Given this list of marker genes TNF, CXCL2, JADE2, SLC1A3, EZH2, SPECC1L, ICAM4, CDK1, GCH1, IL23A, ZC3HAV1, ITGB8, TRAF1, TBC1D10A, RIN2, RNF144B, LDLR, RIPK2, EHD1, HDGF, FFAR2, CYRIA, TMEM54, ADA, PIK3AP1, TNIP1, IL20, SFR1, BIRC3, SMG9, LINC01138, TNFAIP8, DRAM1, PTPRJ, ANO5, TAGAP, HIVEP1, CASP5, ACOD1, UGP2 (UDP-glucose pyrophosphorylase 2), STK26 (serine/threonine kinase 26), CD83, PTGS2, SOCS3, SESTD1, IFNGR2, TNIP3, PIM3, ADORA2A-AS1, CCL20, PLK3, GPR132, EPM2AIP1, ZBTB10, PFKFB3, TANK, CXCL1, IRAK2, IL1B, MMP7, SERPINB9P1, HCAR3, PSMD5, SGPP2, PDSS1, CCL23, PELI1, TNFAIP2, PTX3, NLRP3, RNF19B, RCSD1, PLA1A, TNFRSF9, CXCL8, TAB2, CXCL3, CSF3, EBI3, RHOF, CCL4, ACVR2A, GBP1, ID2, DNAJA1, CENPU, DUSP2, KCNA3, FRMD7, IL10, AQP9, KCNJ2, ZFX (NCBI Gene Id 7543), NOCT, ICAM1, EPB41L3, TNFRSF10B, ARRB1, MTF1, TLR7, BIRC2, SCN1B, RAP2C, SERPINB8, SNX18, PILRA, MIR155HG, EIF1B, CLCF1, TAOK3, RND1, ARL5B (NCBI Gene Id 221079), QKI, BCL2A1, MCOLN2, DCUN1D3, TNFAIP3, PIM2, IL12B, NFE2L2, PMAIP1, HIVEP2, SOD2, BTG3, NAB1, SIAH2, LINC01465, DENND5A, MIR3142HG, HCP5 (NCBI Gene Id 91955), MIR3945HG, SUSD6, SLC2A6, SAV1, PSMA6, PTTG1IP, MAP3K8, PNPLA1, GTF3C6, TNFAIP6, ZC3H12A, CFLAR, IL15RA, PLAC8, RHOU, NFKBIZ, GRAMD1A, TIFA, FNBP1, IL18, LINC01093, G0S2, SYNPO2, CLEC4E, TP53INP1, LINC00528, C11orf96, ACSL1, GADD45A, CD274, MIR9-1HG, HNRNPC, E2F7, DENND4A, CT75, IGSF6, SAMSN1, CLIC4, HCK, IER5, IER3, MARCKS, IL36G, GPR84, AZIN1, STX11 (NCBI Gene Id 8676), MSH6, SMCO4, IL6, NCOA4, PPP1R15B, NBN, RAPGEF2, PLEKHF2, OAZ2, OASL (NCBI Gene Id 8638), PNRC1, PDE4B, IL1A, NFKBIA, LIMK2, NFKB1, C1orf122, RHOH, ANKRD33B (ankyrin repeat domain 33B), SDC4, STAT5A, GIMAP5, here is a description of the gene set: studied in species Homo sapiens Human Gene Set: GSE9988_ANTI_TREM1_VS_LOW_LPS_MONOCYTE_DN from publication Dower K, Ellis DK, Saraf K, Jelinsky SA, Lin LL (PMID 18292579) Genes down-regulated in comparison of monocytes treated with anti-TREM1 versus monocytes treated with 1 ng/ml LPS (TLR4 agonist). TREM-1 is an orphan immunoreceptor expressed on monocytes, macrophages, and neutrophils. TREM-1 associates with and signals via the adapter protein DAP12/TYROBP, which contains an immunoreceptor tyrosine-based activation motif (ITAM). TREM-1 activation by receptor cross-linking is pro-inflammatory, and can amplify cellular responses to Toll-like receptor (TLR) ligands such as bacterial lipopolysaccharide (LPS). To investigate the cellular consequences of TREM-1 activation, we have characterized global gene expression changes in human monocytes in response to TREM-1 cross-linking in comparison to and combined with LPS. Both TREM-1 activation and LPS up-regulate chemokines, cytokines, matrix metalloproteases, and PTGS/COX2, consistent with a core inflammatory response. However, other immunomodulatory factors are selectively induced, including SPP1 and CSF1 (i.e., M-CSF) by TREM-1 activation and IL-23 and CSF3 (i.e., G-CSF) by LPS. Additionally, cross-talk between TREM-1 activation and LPS occurs on multiple levels. While synergy in GM-CSF protein production is reflected in commensurate mRNA abundance, comparable synergy in IL-1b protein production is not. TREM-1 activation also attenuates the induction of some LPS target genes, including those that encode IL-12 cytokine family subunits. Whereas positive TREM-1 outputs are abolished by the PI3K inhibitor wortmannin, this attenuation is largely PI3K-independent. These experiments provide a detailed analysis of the cellular consequences of TREM-1 activation, and highlight some of the complexity in signal integration between ITAM- and TLR-mediated signaling.